Given this list of marker genes ENTREP3, PPIC, NDRG1, F8A1, CD3D, SIPA1, IFIH1, SLCO3A1, FXYD5, ATXN7L3, FRAT1, LPIN1, CCL5, SUN2, CD247, MYO6, DTX1, NBEAL2, EMG1, GALNT10 (polypeptide N-acetylgalactosaminyltransferase 10), MCM5, PADI2, CD28, TANGO2, MS4A6A, PACSIN1, VPS26B, MAP3K4, ACTN1, ELOVL3, SRPK1, SURF4, LAPTM5, KLRD1, HBA2 (NCBI Gene Id 3040), IRF7, SIT1, TMEM38B, NDST2, SATB1, ZYX, ABHD8, EIF2B5, CD27, PRKACB, PLD3, SLC25A25, EIF2D, ITGB7, DUSP2, GADD45A, GNB4, CD3G (CD3 gamma subunit of T-cell receptor complex), CD6, FASLG, PRKCSH, OTUB1, KRT25, ISYNA1, NR4A1, EIF2B4, MYO1F, CSK, TNFSF11, LCK, IQGAP2, SETD4, ZNRF1, MLX, TAP1, STRN4, DTX2, PSTPIP1, ZNF467, GPSM3, JARID2, FAS, KCNN4, RAC2, RFLNB, TNIP1, CST7, CTSW, MYB, ACTN2, ROM1, PBX2, KCNE5, BZW2, PRKD2, MCM3AP, SSBP2, DNTT, AGRN, ITM2C, TNFRSF4, IFIT1B, PITPNM1, BANP, CLN8, TUBA1A, RGS10, NSG2, VPS37B, CBR1, MEPCE, IL4, ACP6, SELL, FYN, CAMK2B, IL18R1, GALNT2, IL7R, OTULINL, JAK3, REXO5, MDP1, TRPC4AP, SUDS3, CCR7, KLK8, LAMTOR4, CTSD, ID2, MARK2, CD5, SPOCK2, CPSF4, SGK1, LTA, ATP6V1E1 (NCBI Gene Id 529), ZAP70, PKP4 (plakophilin 4), SLC29A1, AGTRAP (angiotensin II receptor associated protein), PPP4C, MED24, PMM2 (phosphomannomutase 2), EVL, PHF23, KLF7, TRAF1, NPM3, GTF3C1, TAF1C, ARL4C, HLA-E, DGKA, CA2, NOTCH1, SF1, SFMBT2, ANGPTL2, SPNS1, BOP1, CDK2AP2, ATP13A1, XDH, ITM2A, THY1, MCM7, UNC45A, ADCY6, CRTAM, TNFAIP8L1, CD96, HM13, CD3E, UBA7, PTPN13, KCNAB2, TCF7 (NCBI Gene Id 6932), NAB2, STUB1, DAP, TSPAN6, WRN, NDRG2, WDR83OS, DPF2, MIDN, VSX2, PRKCQ, TLE1, ABCG2, TLE5, RANBP3, RORA, TSPAN32, ICAM2, ACAP1, ISG15, SELPLG, SH2D2A, RGCC, STMN1, NPC2, STIM1, IDNK, here is a description of the gene set: from publication Ji Y, Pos Z, Rao M, Klebanoff CA, Yu Z, Sukumar M, Reger RN, Palmer DC, Borman ZA, Muranski P, Wang E, Schrump DS, Marincola FM, Restifo NP, Gattinoni L (PMID 22057288) Mouse CD8+ T cells affected by ID3 (Inhibitor of DNA binding 3) display patterns of gene expression suggesting enhanced persistance and survival. In this study, we identified genes differentially expressed between ID32a transduced and mock transduced, and ID32a knockout and wild type mouse CD8+ T cells. Most prominent functions of differentially expressed genes include DNA replication-associated repair, maintenance of chromosome stability and mitotic cell divison machinery. Overall, these data suggest that ID3 acts in favor of maintained survival in CD8+ mouse T cells. Genes down-regulated CD8 T cells: mock transduced versus wildtype. Human Gene Set: GSE23568_CTRL_TRANSDUCED_VS_WT_CD8_TCELL_DN species: Homo sapiens